The following is a description of a gene set: The chemical reactions and pathways involving organophosphates, any phosphate-containing organic compound. Human Gene Set: GOBP_ORGANOPHOSPHATE_METABOLIC_PROCESS studied in species Homo sapiens, and this is the list of marker genes: IER3, PDGFA, TMEM86B, SLC4A1, NEIL2, ENTPD1, DPM3, ASMTL, GFPT1, SIRT6, SLC35A1, ABCA8, HIF1A, SCP2, NDUFS4, EFR3A, RPEL1, IDI1, SLC4A4, PIK3CA, ATP5PF, CHAT, DNAJC30, CKB, ADCY10, NUDT19, PIP5K1B, PCYT1B, TPK1, CROT, SDHC, MLXIPL, AASS, ADCY1, MTMR10, ADCY8, PLA2G2A, TDG, GPAA1, PLA2G15, MACROH2A1 (macroH2A.1 histone), CYP2W1, FITM2, SLC25A12, SPTLC1, PRKAG3, NR1H3, PRKAA1, PGAM4, ACOT4, SLC25A22 (NCBI Gene Id 79751), NDUFS3, BMX, PRPSAP1, MFN1 (NCBI Gene Id 55669), ORMDL3, FDPS, NNT, SDHD, AFMID, ADSS2, IP6K1, CEPT1, HSPA1B, PPIP5K2, TAMM41, SERINC1, PLA2G1B, MYH7, PI4KB, MAPDA, PDE9A, PUDP, ATM, B4GALNT2, GATA6, PFAS, GALR2, MTMR6, HK2, NDUFA1, IDH2, RAN, CACNB4, GMDS, DGKQ, ACP3, VNN1, PCYT1A, PLA2G4B, PC, MT-ND2, SULT1A2, ACSM5, BPGM, ELOVL4, NDUFS5, MPC2, MTMR9, PRKG1, XDH, GMPS, CDS1, HK3, SNCA, PLA2G6, NDUFB4, INPPL1, PITPNM1, ACOT12, PTDSS2, TP53, PRPSAP2, DGKE, ABHD14B, HMGCS1, HYCC2, PLCB1, MT-ATP8, NME5, PANK4, ALDH1L2, NAPEPLD, UGDH, ATPSCKMT, ATP5MC2, PGAP4, GFPT2, ACOT11, MIR675, AK8, DPYD, TBPL1, SH3YL1, DOLK, MDH1B, ATP5MC3, AJUBA, UPP1, PCYT2, PDE5A, ABCD1, RAB38, MTMR11, MTMR3, RBKS, UQCC3, BECN1, HADHA, SLC19A2, PDE7A, PMM2, DLST, P2RX7, PLA2G2C, SULT1B1, SPTLC2, ALDH1L1, BLOC1S6, PDE4A, SPHK2, PIGA, PIP4K2C, NTSR1, ABCC9 (NCBI Gene Id 102724274), PLA2G4D, DDHD1, ATP5PO, NDUFC2, PIPOX (NCBI Gene Id 51268), PIGN, PPT2, PLB1, ARNT (aryl hydrocarbon receptor nuclear translocator), GNB3, AK2, ENTPD3, PFKM, CD244, GPI, GPAT2, UPRT, UPP2, NMNAT3, NUDT12, PGK1, MDH2, CSGALNACT1, DPYS, NME9, GNAI3, TSPO, ACSM4, ALOX15, LDHB (NCBI Gene Id 3945), ACSBG2, PLAAT3, PRKAG1, BCL2L13, DIP2A, DDIT4, HSD17B12, SERINC5, HSPA8, GLYCTK (NCBI Gene Id 132158), MAGI3, MVD, NDUFB9, PGK2, SMPDL3A (sphingomyelin phosphodiesterase acid like 3A), LIPA, OGDHL, ASPDH, MFSD8, PIK3C2G, VAC14, ACSM2A, INPP5D, DLAT, PKLR, PRXL2C, PTEN, NT5C3A, UNG, EFR3B, CDS2, MBOAT7, RHOQ, PIP4P2, AGPAT4, GPHN, HKDC1, NUS1, TDO2, ACOT9, NPPB, SHPK, PIP5K1C, AMPD1 (adenosine monophosphate deaminase 1), MYH6, DHDDS, PPT1, FLCN, CPS1, OLA1, IP6K2, PRPS1, MTMR4, GARS1, OC90, ELOVL7, MCCC2, NANS, ITPKC, OSBPL5, ANGPTL3, PIGL, UVRAG, MTCH2, TMEM38B, DHODH, OXSM, SERAC1, NUPR1, PLPPR3, PDK4, AK4, CTPS2, NDUFB6, GMPR2, H6PD, OSBPL10, SARM1, NDUFV3 (NCBI Gene Id 4731), CBFA2T3, GPX4, NMRK2, ACSBG1, PFKFB2, PI4K2B, GK, COASY, IDH1, ATP1B1, PLCG1, MTMR12, CHRM5, GNPNAT1, IGF1, MTMR7, ITPKB, PLAA, NADSYN1, PLD1, NT5C, CETP, LPGAT1, RNASEH2B (NCBI Gene Id 79621), PLD2, GMPPB, DNPH1, PGAP3, GCK, LCLAT1, NAAA, ABCC6, TMSB4X, NUDT4B, IMPA1, MLST8, FIGNL1, PIK3CD, FAR2, MYH4, CMPK2, GFUS, SUCLG1, PIGX, CMAHP, ENPP6, SYNJ2, KAT2B, PIGY, NUDT7, LHCGR (NCBI Gene Id 3973), ENO3, PCSK9, SLC44A4, SPATA18, MBOAT2, PLCE1, PIP5K1A, LGALS13, ATP5MJ, NOX1, DGKK, APOA1, PLAAT5, ACSM2B, IMPDH2, HTD2, LRRK2, NPR2, NDUFV1, DUT, ACSM1, GUCY2D, QPRT, NT5M, PLPPR5, CTPS1 (CTP synthase 1), KMO, PLAAT2, DTYMK, PIK3C2A, PIGK, PNPLA3, LACC1, NDUFA5, MMUT, HTR2A, PDE10A, NT5C1B, ATP6V1A, SLC27A2, LPL, LIPC, HMGCS2, RPE (NCBI Gene Id 96188), NDUFAB1 (NCBI Gene Id 4706), PLPPR4, FHIT, RPTOR, BPNT1, IMPDH1, SULT2B1, PPARA, CBR4 (NCBI Gene Id 84869), PIGO, DGKG, ADSS1, SLC4A7, ENPP1, ATP5MF, PLCL2, SGMS1, CLN8, MOCS1, MOCOS, SLC44A5, GDPD3, APOA2, PRTFDC1, ETNK1, ATP6V0C, PAPSS2, ALDOA, PIK3R3, ANTKMT, BCKDK, MT-ND3, BAAT, PID1, GNPDA2, ELOVL2, HDHD5, PDE7B, PLPP5, SERINC4, GMPR, TRIM63, PRDX6, GLYAT, PNPLA6, PLA2G3, AMPD2, SMPDL3B, SRC, PARG, APP, FKRP, DNAJC19, ABCA3, PTDSS1, ISYNA1, GGPS1, MINPP1, CHPT1, NME4, NUDT3, ABHD8, ELOVL5, PIGZ, PLA2G10, MPI, OGG1, PLCH2, ADA, ACLY, PISD, MYH8, TJP2, SRD5A3, PLA2G4A, MTMR1, XBP1, ABHD16A, PRKCD, SGMS2, APOC2, IL4, PHEX, KARS1, PANK3, ATG14, CLPX, PIPSL, NDUFA11, HDAC4 (histone deacetylase 4), ITPKA, PFKFB4, PIP4K2B, GCDH, PFKFB1, MTHFD2L, THEM5, NAXD, SDHA, AMDHD2, INPP5F, BEND3, APOA4, NAXE, MPPE1 (NCBI Gene Id 65258), SLC25A19, INPP5E, PLA2G4F, MTMR2, PGS1, GSK3A, TREM2, MECP2, NUDT4, IDI2, PTHLH (parathyroid hormone like hormone), FABP5, RORA, GOT1, PNPLA7, ADCY2, PGAP1, IPPK, PRPS2, OSBPL8, ATP1A2, UAP1L1, MT-ND5, UGGT1, CHKA, NDUFB8, AGPAT5, ATP5ME, CWH43, SLC35C1, MTHFD1, ACSF2, INS, GUK1, NR1H4, PSEN1, DOLPP1, PLSCR1, ATP6V1B1, OSBP, PLPP4, TPTE2, ACAT1, GALE, UGP2, GPD2, DGKA (NCBI Gene Id 1606), BPNT2, NUDT2, ME2, GNPDA1, ACMSD (NCBI Gene Id 130013), LPIN1, ETNPPL, DNM1L, ATP5MG, RD3, MFSD2A, PANK1, PTPRQ (NCBI Gene Id 8680), ENTPD4, FOXK2, CKMT1A, OGT, PGAP2, MTMR8, DGKB, XYLB, SLC25A18, PIK3R5, MAP2K1, ATP5F1A, MT-ATP6, ACTN3, THTPA, NMNAT2, ETNK2, PIGP, NDUFB2, PDE4C, SLC30A5, ADPGK (ADP dependent glucokinase), SYNJ1, DCTPP1 (NCBI Gene Id 79077), PIGW, SHMT1, ME1, PLBD2, PDK3, PLA2G2D, EPHA2, NMRK1, NAPRT, PGLS, SULT1C4, GUCA1A, ADCY3, ABCA2, TREX1, EXTL2, RRM1, PIGU, DGKH, CD38, KYNU, NME2, DGKZ, TYMS, ENPP7, SMG1, SMPD2, SCARB1, PDHX, DGAT1, AMPD3, ACSL5, ATP6V1B2, PLA2G4E, ADGRF5, NDUFA7, GAPDHS, HTR2B, CARD11, PDGFB, PDK2, AGPAT2, NDUFA10, PLCB2, UGGT2, STAT3, PIGC, NKX2-1, GPAT4, PDE8A, PIP4K2A, ABHD16B, ADCY7, MPP1, ATP7A, ACSM3, AK1, ATP5F1B, CLN3, EP300, CAD, GK5, PIGG, SMPD3, PIGS, PLA2G2F, SLC52A3, PIGT, IDO2, TPI1, LIPG, ENO2, PGM1, DHTKD1, MOCS2, GPER1, CKMT1B, UPB1 (NCBI Gene Id 51733), GUCY1B1, GDE1, PLA2G2E, SUCLG2, AK5, PGAM2, CDA (cytidine deaminase), ATP5MK, P2RY1, ENTPD2, MOCS3, SH3GLB1, CRYL1, PLPPR2, ADCY9, DCAKD, DMAC2L, PLPP6, TTC7A, PAPSS1, CMPK1, MDH1, PLCB4, AADAT, NUDT15 (NCBI Gene Id 55270, nudix hydrolase 15), RPIA, PDXK, PDK1, NDUFS8, PEMT, TK2, MGAT1, APRT, GOT2, LDHC, INSR, ACSL6, SULT1A3, NDUFA2, HINT1, NUDT8, GTPBP1, MTOR, CDIPT, FABP3, ENO1, GPD1L, NDUFS2, PRKAG2, HACD1, ATP5F1E, ACOT7, CKMT2, SELENOI, UCHL1, REXO2, TPST2, MTMR14, PGD, ELOVL3, AK3, OGDH, CKM, RFK, MVK, G6PD, PMVK, NPR1, PDE2A, PI4KA, SLC19A3, LRGUK, PAICS, ACSS2 (acyl-CoA synthetase short chain family member 2), NME7, PLCB3, NANP, PRPS1L1, SLC25A25, ELOVL1, GPCPD1, TP53I3, NDUFA9, DBI, PFKFB3, PIGH, ACSM6, ITPA, PPCDC, ENPP3, ATP5MC1, PLAAT4, TGDS, OCRL, IMPA2, NFS1, NADK, SMPD1, CAPN2, GPAM, PHB2, NDUFB7, ARL2, ABHD6, PDE8B, SGPP1, LIPI, TPST1, SMUG1, CTNS, PIK3C3, ADCY6, ACO1, SULT1A4, PNLIPRP2, PRKACA, PAFAH1B1, SLC35A3 (NCBI Gene Id 23443), ACOT6, GUCY1A2, G6PC1, PIK3R4, IFNG, CRLS1, PLCD1, HTR2C, DLD, GUCY2C, ACSF3, AK6, NTHL1, PITPNM3, PFKL, SULT2A1, FPGT, ATP5F1C, LDLR, FCSK, ATP5IF1, IPMK, CHKB, ENTPD8, UXS1, VPS9D1, OPA1 (OPA1 mitochondrial dynamin like GTPase), NDUFS7, SDHB, DGKI, NDUFB11, PIK3CG, MT-ND4L, PLA1A, FBP1, AK7, LIPH (lipase H), NUDT18, ALDOB, GK2, PTPMT1, TNFAIP8L3, ZBTB7A, ABHD12B, SLC44A1, NT5C3B, ACSL4, TTC7B, SLC25A13, LPCAT3, FMO2, G6PC3, LCAT, PLBD1, PIGB, UMPS, NT5C2, NAGK, PARP1, HSD17B4, FAM3A, ALPL, GUCY1A1, RAB23, SLC44A2, MCEE, DGKD (NCBI Gene Id 8527), VAPA, FIG4, ATP5F1EP2, CNP, NDUFA6, NEIL1, PRKAA2, FUT8, PARK7, PLPP1, INPP5B, ATP5F1D, NDUFA13, GPLD1 (glycosylphosphatidylinositol specific phospholipase D1), ALOX15B, DPM1, ACOT2, AK9, PTAFR, PIGM, PI4KAP2, MT-ND4, GDA, CASK, FDFT1, NDUFB10, NR1H2, SAMHD1, PDE1A, PLA2G12A, DPM2, SORD (sorbitol dehydrogenase), AGPAT1, MT-ND1 (NCBI Gene Id 4535), FASN, LETMD1, FLVCR1, ITPK1, CHP1, PLPPR1 (phospholipid phosphatase related 1), PLEK, GDPD1 (glycerophosphodiester phosphodiesterase domain containing 1), NMNAT1, DGAT2, NT5E (5'-nucleotidase ecto), SLC25A10, ELOVL6, GALK1, PIK3C2B, PPP2CA, SULT1E1, MLYCD, NUDT17, NUDT13, UCK1, PROCA1, HK1, NUDT11, DCXR, GMPPA, AGPAT3, IDO1, GNPAT, INPP1, FBP2, ABHD12, PGM3, ENTPD7, GUCA1ANB-GUCA1A (NCBI Gene Id 118142757), PNPO, GALM, ACACA, INPP5A, NCOR1, PITPNM2, INPP5J, MYH3, ALDOC, SUCLA2, FITM1, NME3, HACD2, GIT1, UAP1, NUDT14, HSPA1A, PKM, JMJD8, TALDO1, PIGV, NDUFS1, PLCH1, HEXB, IP6K3, ATP5PB, TECR, GUCY2F (NCBI Gene Id 2986), SLC44A3, INPP5K, NUDT5, EFL1, SLC2A6, DGUOK, PMM1, NME2P1, ENO4, NUDT16, PPCS, GPAT3, NADK2, PLAAT1, NDUFA3, EIF6, DCTD, TMEM150A, NAMPT, NDUFA12, FOXK1, RRM2B, PIGF, SELENON (NCBI Gene Id 7800), PTH1R, INPP4B, ACOT1, NFE2L1, ABHD3, NME6, PLA2G5, SLC25A11, PLPP2, TKFC, FLAD1, ATP5PD, GAPDH, SAMD8, PIK3R1, PPARD, G6PC2, NDUFB1, TK1, PDE4B, PIP5KL1, PIP4P1, PPIP5K1, HAAO, FUOM, SMPD4, ADCY5, NDUFC1, PLPP3, ABHD5, INPP4A, PGAM1, ZBTB20, ADSL, NME1 (NCBI Gene Id 7794), ABHD4, ENPP2, PGP, MBD4, PLCG2, GART, AKR1A1, SULT1C3, UCKL1, GIMAP7, UCP2, PTH, NPPC (natriuretic peptide C), PI4K2A, ADK, PON1, NDUFS6, PDHB, PIGQ, PDHA1, BAD, RRM2, PPAT, LDHA, PCK1, PLA2G4C (NCBI Gene Id 8605), DLG1, NDUFB5 (NCBI Gene Id 96666), PNPLA8, FADS1, MIR30C1, ACOT8, TKT, LPCAT4, PIKFYVE (NCBI Gene Id 387568), PDHA2, ADCYAP1R1, AVPR1B, NPPA, COX11, FAR1, ENTPD5, DERA (NCBI Gene Id 51071), NDUFV2, DLG2, P2RY6 (pyrimidinergic receptor P2Y6), PLA2G7 (phospholipase A2 group VII), LPCAT1, NT5C1A, NUDT10, SACM1L, TAFAZZIN, MT-ND6, STOML2, ATIC, TIGAR, CMAS, DCK, HPRT1, LPCAT2, PLCL1, PIK3CB, PANK2, SULT1A1, HMGCR, ACSL1 (NCBI Gene Id 91249), FIS1, MBOAT1, PLA2G12B (phospholipase A2 group XIIB), PNP, TYMP, NUDT9, APOC1, ACSL3, MTM1, NDUFB3, SERINC2, ORMDL1, GPD1, ACACB, ACP6, GALT, UCK2, ADCY4, PINK1, TGFB1, PDE4D, PRKN, NDUFA8, ATP5MGL, ACSS1, PDXP, NOCT, HYCC1, PFKP, GNE, ENSG00000293349, VCP, COL6A1